Given this list of marker genes Pdx1, Hnf4a, Neurod1, Hnf1a, Foxo1, Isl1, Foxa1, Mafa, Nkx2-2, Nkx6-1, Pax6, here is a description of the gene set: Mouse Gene Set: ZHOU_PANCREATIC_BETA_CELL One goal of regenerative medicine is to instructively convert adult cells into other cell types for tissue repair and regeneration. Although isolated examples of adult cell reprogramming are known, there is no general understanding of how to turn one cell type into another in a controlled manner. Here, using a strategy of re-expressing key developmental regulators in vivo, we identify a specific combination of three transcription factors (Ngn3 (also known as Neurog3) Pdx1 and Mafa) that reprograms differentiated pancreatic exocrine cells in adult mice into cells that closely resemble beta-cells. The induced beta-cells are indistinguishable from endogenous islet beta-cells in size, shape and ultrastructure. They express genes essential for beta-cell function and can ameliorate hyperglycaemia by remodelling local vasculature and secreting insulin. This study provides an example of cellular reprogramming using defined factors in an adult organ and suggests a general paradigm for directing cell reprogramming without reversion to a pluripotent stem cell state. studied in species Mus musculus from publication Zhou Q, Brown J, Kanarek A, Rajagopal J, Melton DA (PMID 18754011) Transcription factors expressed in adult pancreatic beta cells.